Given this list of marker genes Pnpla6, here is a description of the gene set: part of: PI Metabolism Reactome Pathway: Glycerophospholipid catabolism electronically inferred by orthology from the curated human pathway studied in species Mus musculus This event has been computationally inferred from an event that has been demonstrated in another species.<p>The inference is based on the homology mapping from PANTHER. Briefly, reactions for which all involved PhysicalEntities (in input, output and catalyst) have a mapped orthologue/paralogue (for complexes at least 75% of components must have a mapping) are inferred to the other species.